Given this list of marker genes PAX3, RTL10, GNB1L (NCBI Gene Id 57800), ONECUT2, PRDM1, WIF1, GLYR1, PRDM14, SHCBP1L, PRRX1 (NCBI Gene Id 5396, paired related homeobox 1), CDKL5, SEMA3A, MARCKSL1, RAB10, EVA1C, ARPP21, FGF17, IKZF2, KCNA5, NRG1, SCNN1A (sodium channel epithelial 1 subunit alpha), NDUFS1, JPH1, MCM7 (minichromosome maintenance complex component 7), PRG4, LRRC8A, TANK, LOXL1, ZMYND8, AP4M1, LRR1 (NCBI Gene Id 122769, leucine rich repeat protein 1), KIF13A (kinesin family member 13A), SMPX, RAB11A, LINC01565, TIAL1, LRRN3, HOXC4, GPD1, TMEM115, SLC6A11, ZNF532, CAMKV, XPNPEP3, CHST9, LUC7L, NPR2, CUZD1, WT1-AS, TSSK1B, KRT222, MYCT1, SRSF6, FERD3L, TSSK3, MAPK6, EEF1B2, OPA3 (outer mitochondrial membrane lipid metabolism regulator OPA3), ERCC6L2, SALL2 (spalt like transcription factor 2), METAP1, HOXA3, PRKAG1, TRIM63, FRY, LMO3, MYL3, NSD1, FAM53C, LZTS2, LSAMP, NNAT, TCF12, ATF7 (NCBI Gene Id 11016), PATL1, ADK, RIMS2, MEF2C, CCN2, ANGPTL2, RRAGD, MIDEAS, SORL1, ROS1, RBM24, ARX, NOTCH4, BTK, HOXC6, EGR1, TRIM54, ATP5MC3, LMOD1, OTX1, UBE3A, BARHL2, CSNK1G1, BDNF, TMOD3, ADNP, MT2A, MBNL2, ATP1A3, LHX6, ST13, SF3B1, MEA1, CDKN2C, SLC7A2, SNX16, TGIF1, ELAVL4, ZNF513, PIK3R1, DCX, MED13, GAB2, NCKAP5, RTKN, DCHS2, NR2F1, WDPCP, SREK1, MYOM3, TRMT9B, TXNIP (thioredoxin interacting protein), SNORC, KCTD15, CHD6, here is a description of the gene set: Human Gene Set: GRE_C Genes having at least one occurrence of the motif GGTACAANNTGTYCTK in the regions spanning 4 kb centered on their transcription starting sites. This matches the NR3C1 transcription factor binding site V$GRE_C (v7.4 TRANSFAC). species: Homo sapiens